The following is a description of a gene set: species: Mus musculus from publication Zhou Q, Brown J, Kanarek A, Rajagopal J, Melton DA (PMID 18754011) Transcription factors expressed in adult pancreatic beta cells. Human Gene Set: ZHOU_PANCREATIC_BETA_CELL One goal of regenerative medicine is to instructively convert adult cells into other cell types for tissue repair and regeneration. Although isolated examples of adult cell reprogramming are known, there is no general understanding of how to turn one cell type into another in a controlled manner. Here, using a strategy of re-expressing key developmental regulators in vivo, we identify a specific combination of three transcription factors (Ngn3 (also known as Neurog3) Pdx1 and Mafa) that reprograms differentiated pancreatic exocrine cells in adult mice into cells that closely resemble beta-cells. The induced beta-cells are indistinguishable from endogenous islet beta-cells in size, shape and ultrastructure. They express genes essential for beta-cell function and can ameliorate hyperglycaemia by remodelling local vasculature and secreting insulin. This study provides an example of cellular reprogramming using defined factors in an adult organ and suggests a general paradigm for directing cell reprogramming without reversion to a pluripotent stem cell state., and this is the list of marker genes: NEUROD1, PAX6, FOXA1, ISL1, HNF4A, HNF1A (NCBI Gene Id 6927), NKX6-1, NKX2-2, FOXO1, PDX1, MAFA